The following is a description of a gene set: Human Gene Set: GOBP_DEVELOPMENTAL_GROWTH_INVOLVED_IN_MORPHOGENESIS The increase in size or mass of an anatomical structure that contributes to the structure attaining its shape. studied in species Homo sapiens, and this is the list of marker genes: SEMA5B, SPG11, POU4F2, NRN1L, TGFBR2, SEMA6C, SPG21, SEMA4D, MEGF8, VCL, TNR, PAK6, TRPC5, CLASP2, NRP1, EPB41L5, PLXNA1, DVL1, CLSTN3, RUFY3, DISC1, YAP1, FGF1, ESR1, BIN3, SLC39A12, PPP3CB, SEMA4F, SYT2, BARHL2, STK11, SPART, EDN1, CTTN, NPR2, NGF, ST8SIA2, CTNNB1, SMURF1, L1CAM, RAPH1, TNC, DIP2B, MAP1B, ZFYVE27, S100B, CXCL12, SLIT2, IFRD1, AREG, APOE, RARG, SIX4, WNT11, SYT4, FSTL4, ADCY10, FGF10, PPP2R3A, SPAG9, CACNG7, ALCAM, MACF1, RGMA, SSNA1, TMEM108, KIF26B, KDM5B, WASF1, C9orf72, RNF157, DRAXIN, NOTCH1, SPP1, VEGFA, SLC23A2, DSCAM, ATG16L1, GOLGA4, SEMA3F, NIN, TGFB1, PLXNA4, EIF2AK4, MED12, CDK5, SOX9, SPRY1, SEMA5A, ADPRHL1, SLITRK1, RIMS1 (regulating synaptic membrane exocytosis 1), IQGAP1 (NCBI Gene Id 8826), APP, WNT3, NRN1, AURKA, ADNP, MUL1, EFNA5, UNC13A, NTN1, NDN, EDNRA, IMPACT, SLIT3, EDN3 (endothelin 3), SYT17, FGF13, RTN4R, LIMK1, SLC9A6, GDI1, PRICKLE1, SFRP1, RNF6, ANAPC2, ARHGAP4, LLPH, SH3GL2, EPHA7, MESP1, SLIT1, GSK3B, SRF, CDKL3, SYT3, NRP2 (neuropilin 2), ITGB1, SPAG6, NTRK3, CYFIP1, BCL11A, LPAR3, BMP4, FN1, RDH10, TFAP2C, KIAA0319, GAREM2, CDKL5, FGFR2, MT3 (metallothionein 3), PUM2, SEMA7A, BMPR2, CDH1, DCC, CSF1, RYK, TRIM28, SYT14P1, NEDD4L, RAB21, PAK1, MAPT, TNFRSF12A, TWF2, SIX1, SEMA3A, OSTN, SPRY2, BDNF, CYFIP2, MED1, HOXD13, PLAA, CDH4, HDAC6, FLRT3, CPNE9, RASAL1, SEMA3G, TBX2, PAFAH1B1, WNT7B, PRKN, CPNE5, CD2AP, TRIM46, CRABP2, PRKCZ, ABL1, TTL, SALL1, WNT5A, VANGL2, TRPV2, SHH, TNN, NDEL1, SHTN1, NLGN3, DDR1, LHX1, NKD1, PTK7, USP9X, EDN2, ULK2, SYT1, SFRP2, ZEB2, ITGA4, MAP3K13, HNF1B, EMX1, SEMA6D, RIMS2, FLRT1, PRKG1, CCL11, LHX2, EXT1, LZTS2, NRCAM, CPNE6, CFL1, DCLK1, DNM2, RTN4, IST1, PTPRS, MAG, OLFM1, MIR195, LAMB2, SIN3A, AUTS2, NKX6-1, COBL, ISLR2, CPNE1, POU4F3, ULK1, MAP2, S1PR1, RND2, PLXNA3, TSC22D4 (TSC22 domain family member 4), ITSN2, POSTN, WNT3A